The following is a description of a gene set: Pulmonary artery dilatation Human Gene Set: HP_PULMONARY_ARTERY_DILATATION species: Homo sapiens An abnormal widening of the diameter of the pulmonary artery., and this is the list of marker genes: ACTA2, IFT56, BGN, ADAMTS19, FBN1, POLR1A, TGFBR1 (NCBI Gene Id 7046), COL5A1, COL3A1, TGFBR2, TLL1, FOXF1, EFEMP2, IPO8 (importin 8)